Given this list of marker genes TROAP, ATP2B4, HSPB2, FCN2, CHRM3, CTSA, UPK2, POSTN, CD3E, PTPN18, DGAT1, NKG7, IRGC, SLC27A2 (NCBI Gene Id 8523), NPR3, TAF1C, SEC31B, LMO3, AK4, PDPK1, CDIPT, ITGB8, KCNJ6, WARS1, BTBD2, PTGIS, SLC7A4, FERMT2, PTPRT, ATP4B, FCGR3A, EFNA1, PEX12, LTBP1, ENOX2, COL13A1, C2orf72, FURIN, ZNF318, CDH18, HLA-DRB6, AKR1C3, SLC8A1, CXCL3, FRMD4B, KDM2A, MAOA, CHRNE, IAPP, RGS14, SERPINB1, ADGRB3, CAMTA1, HGF, SCHIP1, BEAN1, RENBP, SLC6A4, CBFA2T3, PRL, PRRC1, RLF, IL18RAP, SPAG9, ALOX12B, SYP, DNAH17, HRK, RS1, SOCS7, NFKBIL1 (NCBI Gene Id 4795), ZFPL1, MICAL2, RFNG, GZMH, GNPAT, KRT5, ELP4, SULT4A1, GDF5, SYT11, PLA2G4C, SUPT5H, EML1, CBLIF, ZNF510, CUBN (cubilin), SMARCB1, RET, SULT2A1, SLC1A3, ZNF592, H6PD, FZD7, FKBP9, ADRB3, STAB1, IFI30, GRK1, COL11A1, ANKRD7, RRAS, ACADL, MYEF2, SLC9A8, FADS3, WRN, CD8A, CCIN, NRG2, H1-4 (H1.4 linker histone, cluster member), HS3ST1, TAOK3, GALNT2, PPP1R15A, MUSK, RGR, NBR1, L3MBTL1, GZMB, P2RY11, TACR1, IMPG1, RCHY1, SFRP4, CASP2, STAT6, MAGEA1, CAMK2G, RNF13, MEF2C, SPINK1, CCNYL7, FAM89B, AURKC, ICAM1, FSTL4, SLC5A4, GNA15, NUAK1, PLCE1, NEU1, ZNF20, NMT1 (N-myristoyltransferase 1), B3GALT4, GFPT2, DNM2, SCNN1A, MBNL2, IRF4, PRAF2, MIA, GRM3, LPAL2, CHRNA6, ITGAX, PKP2, PIGA, LAG3, RASAL2, RIT2, TWF1, ADAMTSL2, APBB3, VIPR1, RPP14, DHX29, IL7R, RING1, HLA-DQB1, MAGEA5P, TCEA2, IFNG, CD4, CDKN1B, ZNF623, ZNF415 (zinc finger protein 415), DLG2, GEMIN4, FZD9, AGXT, SERPINC1, FABP3, LDLRAD4, JRK, WASL, SEPTIN10, CDK3, ME1, RNF126 (ring finger protein 126), SLC6A3, PAX7, BMP3, SOCS3, LCT, CHD2, GRIK1, CHRND, here is a description of the gene set: Systemic lupus erythematosous (SLE) is an autoimmune disease with an important clinical and biological heterogeneity. B lymphocytes appear central to the development of SLE which is characterized by the production of a large variety of autoantibodies and hypergammaglobulinemia. In mice, immature B cells from spontaneous lupus prone animals are able to produce autoantibodies when transferred into immunodeficient mice, strongly suggesting the existence of intrinsic B cell defects during lupus. In order to approach these defects in humans, we compared the peripheral B cell transcriptomes of quiescent lupus patients to normal B cell transcriptomes. from publication Garaud JC, Schickel JN, Blaison G, Knapp AM, Dembele D, Ruer-Laventie J, Korganow AS, Martin T, Soulas-Sprauel P, Pasquali JL (PMID 21886837) species: Homo sapiens Genes down-regulated in B lymphocytes: systemic lupus erythematosous (SLE) versus healthy. Human Gene Set: GSE30153_LUPUS_VS_HEALTHY_DONOR_BCELL_DN